Given this list of marker genes MIR125A, MIR210, C5AR1, HMGB1, JUP, ENG, ERBB2, HMGA2, CREB3L1, MIR487B, TNN, ADGRG6, MIR494, GHRL, NODAL (nodal growth differentiation factor), RHOJ, CTNNB1, MDK, SEMA6A, HSPB1, CLIC3, CCR3, NRP1, QKI, ADGRB2, MIRLET7G, NPPB, EPN2, WNT4, VASH2, HIF1A, MIR29C, MIR29A (NCBI Gene Id 407021), APLNR, MIR205, JCAD, KRT1, CXCL10, THBS2, PLXND1, NOS3, MIR193A, MIR505, E2F2, PROK1, ITGB8, COL4A2, MIR329-1, PGK1, ERAP1, MIR23A, ADAM12, MIR30C1, RLN2, HGS, DLL1, WARS2, CD40, TNFRSF12A, MIR10A, FUT1, CXCL12, ADGRB3, GAB1, CXCR4, MIR27B, SIRT1, SIRT6, MIR424, MIRLET7B, KLF2, CXCR3, APOH, STARD13, MIR222, MIR137, AKT3, MIR200B, ITGAX (NCBI Gene Id 3687), MIR939, LRG1, NF1, ITGA5, ABL1, SPHK1, ISL1, EMILIN1, MIR1224, PRKD2, OPTC, ADM, PRKD1, CHI3L1, PRKCA, MAPK7, SMAD1, JMJD8, EMILIN2 (elastin microfibril interfacer 2), SPRY2, IL10, MIR138-1, MIR92A1, EPHA1, RUNX1, HIPK2, RNH1, HIPK1, SULF1, EMP2, MIR1-1, VEGFB, PDPK1, CYBB, HOXA5, DDAH1 (NCBI Gene Id 23576), KLK3, TGFBR2, WNK1, TSPAN12, TGM2, IL17F, CXCL13, TERT, CNMD, FGF1, ADGRB1, MIR199A1, PDCD10, MIR19A, DCN, PDCL3, SYNJ2BP, PRL, TBXA2R, ADAMTS1, VASH1, CMA1 (chymase 1), GPNMB, PML, BRCA1, SEMA3E, RHOB, FOXC1, SMOC2, HTN1, MIR451A, GADD45A, ZNF304, IL6, MINAR1, MIR503, VEGFC, MIR15A, CCL24, PKM, GATA4, GDF2, TNFAIP3, FGF2, MIR34B (NCBI Gene Id 407041), MIR30B, NPR1, RAMP2, PTPN6, MIR125B1, SEMA5A, HYAL1, MIR18A, AQP1, RECK, TEK, CD36, MIR375, PIK3CD, MIR130A, MIR20B, TJP1, F3, MIR20A, EMC10, SP1, NTRK1, MIR223, TLR3, OR10J5, ANGPTL4, RELA, IL1A, SERPINE1, CEMIP2, MIR126, RGCC, ATP2B4, SHC1, FKBPL, GATA6, PAK4, ECSCR, ADM2, MTDH, MIR377, ACVRL1, CAMP (NCBI Gene Id 820), IL1B, SERPINF1, MIR31, CELA1, MIR30A, MIR101-1, COL4A3, BTG1, MIR181B1, CYP1B1, MIR495, SFRP1, CTNND1, ATF2, RTN4, MIR34A, CX3CL1, TGFB2, EGLN1, MIR30E, CD160, ITGB1 (NCBI Gene Id 3688), PIK3R6, HSPB6, ANXA3, MECP2, RRAS, CCBE1, MIR378A, PF4, HSPG2, AGO1, GATA2, GRN, SPINK5, MIR492, PDE3B, SP100, DAB2IP, PTPRM, DSG2, ADAMTS9, GREM1, EFNA1, MIR361, WARS1, THBS4, SFRP2, PIK3CG, KLF4, FBLN5, TNFSF12, MIR24-1, ZNF354C, ZC3H12A, TIE1, KDR, PRKCB, C3, PLCG1, SASH1, MIR214, HHEX, C3AR1 (complement C3a receptor 1), ABCC8, LEP, CDH5, THBS1, ECM1, MIR143, FOXJ2 (forkhead box J2), CCM2, GTF2I (NCBI Gene Id 90875), AMOT, STAT3, HRG, CEACAM1, NINJ1 (NCBI Gene Id 4814), MIR199B, KRIT1, EFNA3 (NCBI Gene Id 1944), PPARG, MIR15B, SEMA4A, TNMD, PTGIS, FASLG, ANGPTL3, CLDN5, ADGRA2, NFE2L2, NAXE, ALOX5, CCR2, MIR132, PTK2B, TAFA5, YJEFN3, MIR640, MIR145, MIR16-1, PPP1R16B, FOXO4, MIR221, MIR34C, PLK2, SLC12A2, FLT1, EPHA2, AGO2, XBP1 (X-box binding protein 1), ITGB2, MIR106B, SPARC, BMPER, EPN1, MIR185, ID1, ANGPTL7, ANGPT2, MIR99B, MYDGF, TWIST1, PDCD6, ROCK1, TGFB1, S100A1, SARS1, CCN6, GHSR, GLUL, MIR146A, GPR4, HMOX1, TSPAN18, HK2, RAPGEF3, ETS1, WNT5A, HLA-G, MIR212 (NCBI Gene Id 406994), PIK3CB, MIR21, TGFBR1, STAT1, MIR1908, STAB1, MIR885, STIM1, NR2E1, MIR17 (microRNA 17), ROCK2, FYN, CD34, ADAM10, FGF18, TMIGD2, JAK1, APELA, AGGF1, CXCL8, MIR1298, TNF, CX3CR1, ISM1, CCL11, ANGPT4, FGF16, CHRNA7, SPRED1, MIR217 (NCBI Gene Id 406999), VEGFA, FOXC2, ITGB3, here is a description of the gene set: Human Gene Set: GOBP_REGULATION_OF_VASCULATURE_DEVELOPMENT studied in species Homo sapiens Any process that modulates the frequency, rate or extent of vasculature development.